The following is a description of a gene set: from publication Chen Y, Wang X (PMID 31504780) Human Gene Set: MIR4697_5P species: Homo sapiens Genes predicted to be targets of miRBase v22 microRNA hsa-miR-4697-5p in miRDB v6.0 with MirTarget v4 prediction scores > 80 (high confidence targets)., and this is the list of marker genes: SCRT1, RLBP1, FOXP4, NFIX, RHOG, EFNB1, IQSEC2, SLC8A2, NRG1, IGF2, NFIC, PDGFB, MELTF, CARMIL1, MDGA1, HPD, ADGRL1, NAT8L, WNT1